Given this list of marker genes RLIG1, RTP1, DMTN, DHTKD1, RHD, PLXDC1, BGLAP, FN3K, DNAJB3, GBP6, KLF5, GPSM2, OSGEPL1, NTN4, FAM234B, PCCB, BCAM, C1QTNF12, NAGS, OR10X1, GPC4, MMP9, ASPRV1, MYLK3, TEX264, COL5A1, TTC39A, CHST10, DUSP8, RANBP17, SCRN3, GSTP1, CCDC74B, MBOAT2, BLVRB, LCN2, SLC6A20, PDE4A, CAMSAP2, KEL, EMC9, CREB3L2 (NCBI Gene Id 64764), S100A9, ANK1, AIFM2, OAS1 (NCBI Gene Id 4938), ZNF821, OASL, RYK, IRF7, MFHAS1, TRIM2, FHDC1, IGSF3, NQO1, CES2, MARCHF8, EYA4, MMP14, GOLM1, RETNLB, SLC29A1, CENPV, BTRC, SLC22A23, LCAT, TSPO2, TSPAN15, SLC7A7, TLCD4, GAL, LMCD1, MGST3, YPEL4, CNTF, REC8, DYNC2I1, PTK2, CD177, C8orf88, ADGRL2, SLC38A5, AGTR1, AGPAT4, LY6K, TRIM17, ALAS2, DCLK2, PARM1, PDIA2, ZFP36L1, SHISA9, C17orf99, ZNF316, SPIRE1, MEGF9, SEMA6A, BDH1, EPDR1, SH3TC2, C15orf48, C3orf80, S100A8, CHAC2, IGKV1D-43, SEPTIN8 (septin 8), FHIT, SLC25A51, MYL11, NSMCE3, YAE1, PLPP1, KRTCAP3, TSPAN33, ASNS, SEPTIN4, SORBS1, FNTB, ACP1, DKKL1, SLC12A4, SMIM1, MLF1, CARHSP1, LMNA, MATCAP2, HEBP1, MGLL, PHYHIP, MXD3, AMPD3, GNA14, VAMP1, ZG16, SLC39A8, ENPP3, SLC11A2, MMP8, CD82, LTF, ACOT6, KLK1, CELA1, PM20D2, PXMP2, ERFE, GML, C2orf69, DNASE2, ZBTB46, CHIA (NCBI Gene Id 27159), GTF2H4, H3-3A, TMEM72, RAB3IL1, PAQR9, KLHDC8B, EVI5, BCL2L15, GDPD1, PHLDA2, CETN4P, CDR2, IFITM3, ZNF703, ACKR1, TRIM10, PGAP3, AHCYL2, PIH1D2 (PIH1 domain containing 2), RNF128, LKAAEAR1, AGAP1, GAREM1, PIK3R2, ELL2, HPSE2, RGS7BP, NIPA1, CAMP, ALDH1A1, MFSD9, FCMR, UBLCP1, ISG20, WDSUB1, PPP2R5B, RECQL4, P4HA2, SQOR, RADX, PC, LRRC36, TARS3, LPIN1, SESN2, TUBA8, EPB42, METTL8, ATP7B, CYP4F22, TNS1, NXPE4, SLC30A10, MARVELD2, SPHK1, SAMD11, WFDC21P, SLC38A9, FZD7 (NCBI Gene Id 8324), SLC41A3, NFIA, TSPAN8, H2BC27P, UBAC1, PGAP6, C1orf198, GLS2, CLCN2, CARMIL3, KCNAB1, BTNL10P, CTSE, PAQR4, SLFN12, AGPAT3, AQP11, ARHGEF25, IGF2R, HPN, RHAG, SEC14L2, HOMER2, ABCA3, NEFH, TAC3 (tachykinin precursor 3), TKTL1, SH2D4A, ABCG4, RFESD, TINAGL1, CLDN4, TRAK2, SLC46A3, PPM1L, TFR2, WRN, CNN1, here is a description of the gene set: Genes down-regulated in immature bone marrow progenitor cells upon knock out of CBFA2T3. from publication Chyla BJ, Moreno-Miralles I, Steapleton MA, Thompson MA, Bhaskara S, Engel M, Hiebert SW (PMID 18710942) studied in species Mus musculus Human Gene Set: CHYLA_CBFA2T3_TARGETS_DN While a number of DNA binding transcription factors have been identified that control hematopoietic cell fate decisions, only a limited number of transcriptional corepressors (e.g., the retinoblastoma protein and the nuclear hormone corepressor) have been linked to these functions. Here, we show that the transcriptional corepressor Mtg16 (myeloid translocation gene on chromosome 16), which is targeted by t(16;21) in acute myeloid leukemia, is required for hematopoietic progenitor cell fate decisions and for early progenitor cell proliferation. Inactivation of Mtg16 skewed early myeloid progenitor cells toward the granulocytic/macrophage lineage while reducing the numbers of megakaryocyte-erythroid progenitor cells. In addition, inactivation of Mtg16 impaired the rapid expansion of short-term stem cells, multipotent progenitor cells, and megakaryocyte-erythroid progenitor cells that is required under hematopoietic stress/emergency. This impairment appears to be a failure to proliferate rather than an induction of cell death, as expression of c-Myc, but not Bcl2, complemented the Mtg16(-/-) defect.